The following is a description of a gene set: Basigin interactions Mouse Gene Set: REACTOME_BASIGIN_INTERACTIONS studied in species Mus musculus, and this is the list of marker genes: Itga3, Spn, Bsg, Slc7a7, Mag, Atp1b3, Slc7a6, Ppil2, Slc16a8, Slc3a2, Mmp1a, Slc16a1, Atp1b2, Atp1b1 (ATPase, Na+/K+ transporting, beta 1 polypeptide), Ppia, Slc16a3, Itga6, Slc7a10, Slc7a9, Slc7a8, Slc7a11, Itgb1, Cav1, Slc7a5